Given this list of marker genes ABCC3, LDLR, SLC22A1, RXRA, ABCG8, HMGCR, NR1H4, ATP8B1, SLCO1A2, ABCG5 (ATP binding cassette subfamily G member 5), ABCC4, NR1I3, ABCB11, ABCB4, ABCC2, EPHX1, TJP2, SLC10A1, SCARB1, here is a description of the gene set: Cholestasis studied in species Homo sapiens Human Gene Set: WP_CHOLESTASIS